Given this list of marker genes Bhmt-ps1, Prdx6-ps2, Cngb3, Cnbd1, Gm27243, Pnisr, Ccnc (NCBI Gene Id 53854), Fbxl4, Gm24042, Gm11905, Tpm3-rs2 (tropomyosin 3, related sequence 2), Manea, Gm30731, Gpr63, Cpne3, Nkain3, Gm11868, Mms22l, Klhl32, Ndufaf4, Gm11911, 4930480G23Rik, Gm11889, 1700025O08Rik, Ttpa, Gm11884, Gm11877, Gm11895, Fhl5, Gm11873, Gm12354 (predicted gene 12354), Ufl1, Gm11871, Gm11914, Wwp1, Pou3f2, Fut9, Faxc, Rmdn1, Atp6v0d2, Gm11853, Ggh, Gm24965, Gm11897, Gm12393, Gm11892, Gm11893, Coq3, Usp45, Gm25977, C230012O17Rik, Slc7a13, Gm11903, Gng2-ps1, Gm11885, Gm11875, Tstd3, Gm25173, Prdm13, Gm25975, 4930548K13Rik, Mmp16, Gm11878, Gm24977, Gm11888, Gm12353, Gm11882, Gm24607, Gm11872, Gm11896 (predicted gene 11896), Gm11860, here is a description of the gene set: species: Mus musculus Mouse Gene Set: chr4A3